The following is a description of a gene set: S1P4 pathway studied in species Homo sapiens from publication Schaefer CF, Anthony K, Krupa S, Buchoff J, Day M, Hannay T, Buetow KH (PMID 18832364) Human Gene Set: PID_S1P_S1P4_PATHWAY, and this is the list of marker genes: GNAI3, GNA12, MAPK1 (NCBI Gene Id 5594), CDC42, S1PR5, GNAI2, PLCG1, GNAI1, RHOA, GNA13, GNAO1, MAPK3, GNAZ, S1PR4